The following is a description of a gene set: part of: Post-translational protein modification Reactome Pathway: Post-translational modification: synthesis of GPI-anchored proteins This event has been computationally inferred from an event that has been demonstrated in another species.<p>The inference is based on the homology mapping from PANTHER. Briefly, reactions for which all involved PhysicalEntities (in input, output and catalyst) have a mapped orthologue/paralogue (for complexes at least 75% of components must have a mapping) are inferred to the other species. electronically inferred by orthology from the curated human pathway species: Mus musculus, and this is the list of marker genes: Thy1, Gpihbp1, Nrn1, Ly6e, Alpi, Pigp (phosphatidylinositol glycan anchor biosynthesis, class P), Ly6d, Cpm, Cd52 (CD52 antigen), Lypd4, Pigs, Mdga1, Pigf, Pigx, Msln, Pigyl, Spaca4, Mdga2 (MAM domain containing glycosylphosphatidylinositol anchor 2), Folr2, Pigg, Ly6h, Lypd5, Tectb, Piga, Ceacam1, Nrn1l, Prss41, Lypd2, Lypd3, Pigt, Ly6k, Alpl, Cd109, Ceacam2, Plaur, Sprn, Psca, Plet1, Psg29 (NCBI Gene Id 114872), Pigb, Rtn4rl2, Cntn3, Meltf, Pigv, Lypd8, Pigz, Negr1, Vnn1, Pigl (phosphatidylinositol glycan anchor biosynthesis, class L), Reck (NCBI Gene Id 53614), Psg22, Gp2, Ly6g6c, Otoa, Ulbp1, Pigw (phosphatidylinositol glycan anchor biosynthesis, class W)